The following is a description of a gene set: Binding to a ubiquitin conjugating enzyme, any of the E2 proteins. Human Gene Set: GOMF_UBIQUITIN_CONJUGATING_ENZYME_BINDING studied in species Homo sapiens, and this is the list of marker genes: PPARA, MARCHF6, FOXL2, RNF14, SIAH3, RNF144B, UBE3D, DCUN1D3, PRKN, MARCHF7, ZMYM2, RNF125, SIAH2, UBE2V1, ARIH2, DCUN1D4, RNF19A (NCBI Gene Id 81036), ARIH1, SIAH1, TRIM72 (tripartite motif containing 72), TOLLIP, RNF19B, RNF180, GRIK2, AUP1, RNF217 (NCBI Gene Id 154214), DCUN1D5 (NCBI Gene Id 84259), DCUN1D2, ANKIB1, TRAF6, DCUN1D1, RNF144A